Given this list of marker genes BRAF (NCBI Gene Id 673), BIN1, AKT1, NOTCH1 (notch receptor 1), MAP2K2, KRAS, USF3, MTMR14, KLLN, GNPTAB (N-acetylglucosamine-1-phosphate transferase subunits alpha and beta), MYF6, RNU4-2, PIK3CA, DNM2, ESCO2, THSD1, PDCD10, KRIT1, CCM2, RYR1, SDHD, SDHC, TEK, NRAS, ATP2B1, PTEN, HOXD13, MAP2K1, IDH1, HRAS, SEC23B, SDHB, here is a description of the gene set: Cavernous hemangioma species: Homo sapiens Human Gene Set: HP_CAVERNOUS_HEMANGIOMA The presence of a cavernous hemangioma. A hemangioma characterized by large endothelial spaces (caverns) is called a cavernous hemangioma.